The following is a description of a gene set: The process in which amyloid-beta is removed from extracellular brain regions by cell surface receptor-mediated endocytosis, followed by intracellular degradation. studied in species Mus musculus Mouse Gene Set: GOBP_AMYLOID_BETA_CLEARANCE_BY_CELLULAR_CATABOLIC_PROCESS, and this is the list of marker genes: Lrp1, Ide, Ldlr, Abca7 (NCBI Gene Id 27403), Mme, Cd36, Trem2, Lrp4